Given this list of marker genes DMRTC2, HP1BP3, SETD7, MECOM, SETDB2, SETDB1, LOXL2, PRDM16, TRIP12, SNAI1, UBR5, MTHFR, here is a description of the gene set: species: Homo sapiens Human Gene Set: GOBP_HETEROCHROMATIN_ORGANIZATION Any process that results in the specification, formation or maintenance of the physical structure of eukaryotic heterochromatin, a compact and highly condensed form of chromatin.